The following is a description of a gene set: mouse primary BMDCs were stimulated with tlr ligands and gene expression changes were profiled on Affymetrix arrays Human Gene Set: GSE17721_CPG_VS_GARDIQUIMOD_6H_BMDC_UP from publication Amit I, Garber M, Chevrier N, Leite AP, Donner Y, Eisenhaure T, Guttman M, Grenier JK, Li W, Zuk O, Schubert LA, Birditt B, Shay T, Goren A, Zhang X, Smith Z, Deering R, McDonald RC, Cabili M, Bernstein BE, Rinn JL, Meissner A, Root DE, Hacohen N, Regev A (PMID 19729616) Genes up-regulated in comparison of dendritic cells (DC) stimulated with CpG DNA (TLR9 agonist) at 6 h versus DC cells stimulated with Gardiquimod (TLR7 agonist) at 6 h. species: Homo sapiens, and this is the list of marker genes: MX2, PRP4K, SLC29A4, ATP11B, ADAP2, BAIAP2 (BAR/IMD domain containing adaptor protein 2), MAX, ICOS, SPP2, TFG, FGB, CXCR2 (C-X-C motif chemokine receptor 2), IRX5, C5orf47 (chromosome 5 open reading frame 47), ACER2, MGLL, MOCS2, SLC28A2, CD40, IL10RA, HIBADH, LRRC56, DEPTOR, TRIM21, NOTCH2, RRAS2, IFNB1, FGF23, CEP131, PIM1, ACADSB, MMP7 (matrix metallopeptidase 7), NFIX, ERAS, IL12B, TREM2, PRG4, TENT2, IGBP1, PPIF, ZKSCAN5, ACAD9, TAGLN, DMPK (DM1 protein kinase), LPAR1, HAT1, NUP58, IL6, ATF3 (activating transcription factor 3), CHAC2, TRA2B, MOV10, LPO, CDKN2C (cyclin dependent kinase inhibitor 2C), RETN, AFG2A, MYLK, DIO1, B4GALNT1, PHF13, TMEM128, LRAT, GPX7, RBM17, KCNAB3, PHIP, FN3K, NAA20, GSTO1, HFE, PLEKHA2, RGS1, MACROH2A1, PTTG1, HMGN3, ITGA8, MACIR, CSNK1A1, PRX, TFAP4, SNX2, IFIT3 (NCBI Gene Id 8376), LAMB3, MAL, RPL22L1, SGK1, DDX60, DSP, CPEB3, BLOC1S6, LOXL3, METRNL, PDGFA, PLIN2, NAT1, FMR1NB, IFIH1, SLC35E4, FANCA, CSF1, PLOD3, NCOA1, G3BP2, EPN2, HPCAL1, TYMS, PELI1, NUDT9 (NCBI Gene Id 79013), PIGF, HOOK2, RABEPK, CDC42EP4, CDX4, ANKRD17, RRAGC (NCBI Gene Id 64121), SNW1, CES1, SOCS6, PNPT1, DVL2, NOS1 (nitric oxide synthase 1), STK39, BIRC3, THEMIS2, PCBP1, SLC30A7, GRK1, ITGB7 (NCBI Gene Id 3695), SCN7A, OSGIN2, LIPT1, TAS1R1, PRPF38A, ETNK1, CAND1, INSL6, CASP4, GPC6, HIGD1B, SIAH2, STAMBP, HBEGF, IK, NECTIN2, IFT22, ZNF106, ARL4A, GTPBP2, MYD88, PLA2G1B, TMEM158 (NCBI Gene Id 25907), CASR, AKAP3, GHITM (NCBI Gene Id 27069), LORICRIN, C1orf35, CCL2, FSCN1, GMPPB, TIAM1, PTGER4, MRPS7 (mitochondrial ribosomal protein S7), ELOA, TMEM39A (NCBI Gene Id 55254), MRPL54, RARS1, HLA-B, MRPS6, ODF2L, HOXB4 (homeobox B4), CCDC167, INTS4, PPM1D, BTBD3, OGFR, NT5C3A, KPNA3, STARD8, KCNAB1, BATF, SDF2L1, ENDOD1 (endonuclease domain containing 1), SELE, PELO, KDR, FAH, RFXANK, CTTN, CACNB4, RITA1, SLC6A8, ARAP2, UBA7, SERPINC1, CXCR5, LAG3, MYH6, FGFR1, FBH1